Given this list of marker genes VAC14, TBX5, FIG4, KCNN3, EOGT, here is a description of the gene set: Absence of the distal phalanges of the toes. Human Gene Set: HP_APLASIA_OF_THE_DISTAL_PHALANGES_OF_THE_TOES Aplasia of the distal phalanges of the toes species: Homo sapiens